Given this list of marker genes WNT2B, FAM13B, WASH9P, ZKSCAN8, C1S, ZNF330, ZBTB20, TSPYL1, RNF146, ARMCX1, LINC00205, PALM2AKAP2, S100PBP, TIMP3, TTC28, TMEM237, SRGAP2, LXN, SPAG9, PRNP, PDGFD, SLC30A4, SPOCK2, RBMS1, CERK, NDN, NR2F1, BEX4, SULF1, UBE2E2, SLIT2, WASF3, CPVL, HOXD8, KAT2B, ARNT, POLR2M, PLA2G12A, PRPS1, EXTL2, GSDME, CSGALNACT2, TGFB2, CCDC50, PLSCR3, CALD1, CPE, FGF13, TMX4, FERMT2, WNT5A, RGL1, GLI3, NLRP1, BASP1, GPNMB, TCEAL1 (NCBI Gene Id 96422), SLC39A10, IFI16, FZD7, DSE, PLEKHM3, CLIP4, MAGI2-AS3, FAM153A, FBXL7, DAB2, SBSPON, SMIM10L2A, HBB, TCF4, CAV1, TAOK1, C1orf198, CAP2, PSIP1 (PC4 and SRSF1 interacting protein 1), KIF1B, TIAM1, OSTM1, PTPN12, PREPL, UFSP2, REEP1, RUBCNL, BNIP2, NUCKS1, SOD2, DPYSL3, MNDA, IRF2BPL, PNMA8A, WDFY3, PLSCR4, MAP3K8, CFL2, STK26 (serine/threonine kinase 26), GAS1, KDR, TCEAL3, CANX (calnexin), EIF3M, BLOC1S6, BTF3L4, IGFBP6, UGP2, CRLS1, RSRP1, EPC2, CALM2, RERG, DOK5 (NCBI Gene Id 87149), GPRASP1, CELF2, REC8, SIRPA, FLRT2, PTGS1 (NCBI Gene Id 5742), DCN, PLPP1, PROCR, DPYD, HTRA1, CCDC80, DDX5, SPRY1, XPO1, DCBLD2, ZYG11B, WT1, SDC2 (syndecan 2), TALAM1, KPNA5, HNRNPD, ZFPM2, PMP22, RUNX1T1, CBR4, NELL2, ZNF532, ADH5 (alcohol dehydrogenase 5 (class III), chi polypeptide), MCOLN3, PTPN21, LGALS8, SOCS5, CDON, ACSS3, MAF (MAF bZIP transcription factor), LIX1L, HSP90AB1, HDAC4, BNC2, ST13, LAMA4, EFHC1, DDR2, ATP2B1, GCA, SH3BP5, LINC01116, CTSK, IFT52, GET1, FRAS1, RAB11FIP3, OLFML1 (olfactomedin like 1), PDGFC, PRKAR1A, PROS1 (protein S), ZNF286A, TMEM45A, LONRF2, AJUBA, FLNC, COL8A1, PPM1K, CRYBG3, NKX3-1, GPRASP2, EFEMP1, SEC11A, EPB41L5, DOCK11, RBFOX2, ZNF641, RAB11FIP2, ATP11C, PKD2, FER, AASDHPPT, FBXO21, FBXL3, GABPA, ZNF512, ZNF483, ATF1, SOX6, RCHY1, MYH10 (NCBI Gene Id 4628), AP1S2, here is a description of the gene set: PURPOSE: To elucidate the molecular mechanisms contributing to the unique clinicopathologic characteristics of mucinous ovarian carcinoma, global gene expression profiling of mucinous ovarian tumors was carried out. EXPERIMENTAL DESIGN: Gene expression profiling was completed for 25 microdissected mucinous tumors using Affymetrix U133 Plus 2.0 oligonucleotide microarrays. Hierarchical clustering and binary tree prediction analysis were used to determine the relationships among mucinous specimens and a series of previously profiled microdissected serous tumors and normal ovarian surface epithelium. PathwayAssist software was used to identify putative signaling pathways involved in the development of mucinous LMP tumors and adenocarcinomas. RESULTS: Comparison of the gene profiles between mucinous tumors and normal ovarian epithelial cells identified 1,599, 2,916, and 1,765 differentially expressed in genes in the cystadenomas, LMP tumors, and adenocarcinomas, respectively. Hierarchical clustering showed that mucinous and serous LMP tumors are distinct. In addition, there was a close association of mucinous LMP tumors and adenocarcinomas with serous adenocarcinomas. Binary tree prediction revealed increased heterogeneity among mucinous tumors compared with their serous counterparts. Furthermore, the cystadenomas coexpressed a subset of genes that were differentially regulated in LMP and adenocarcinoma specimens compared with normal ovarian surface epithelium. PathwayAssist highlighted pathways with expression of genes involved in drug resistance in both LMP and adenocarcinoma samples. In addition, genes involved in cytoskeletal regulation were specifically up-regulated in the mucinous adenocarcinomas. CONCLUSIONS: These data provide a useful basis for understanding the molecular events leading to the development and progression of mucinous ovarian cancer. Genes down-regulated in mucinous ovarian carcinoma tumors of low malignant potential (LMP) compared to normal ovarian surface epithelium tissue. from publication Wamunyokoli FW, Bonome T, Lee JY, Feltmate CM, Welch WR, Radonovich M, Pise-Masison C, Brady J, Hao K, Berkowitz RS, Mok S, Birrer MJ (PMID 16467078) Human Gene Set: WAMUNYOKOLI_OVARIAN_CANCER_LMP_DN studied in species Homo sapiens